The following is a description of a gene set: from publication Creighton CJ, Massarweh S, Huang S, Tsimelzon A, Hilsenbeck SG, Osborne CK, Shou J, Malorni L, Schiff R (PMID 18794137) Human Gene Set: CREIGHTON_ENDOCRINE_THERAPY_RESISTANCE_1 studied in species Homo sapiens The 'group 1 set' of genes associated with acquired endocrine therapy resistance in breast tumors expressing ESR1 and ERBB2. The effectiveness of therapies targeting specific pathways in breast cancer, such as the estrogen receptor or HER2, is limited because many tumors manifest resistance, either de novo or acquired, during the course of treatment. To investigate molecular mechanisms of resistance, we used two xenograft models of estrogen receptor-positive (ER+) breast cancer, one with and one without HER2 overexpression (MCF7/HER2-18 and MCF7 wt, respectively). Mice with established tumors were assigned to the following treatment groups: estrogen supplementation (E2), estrogen deprivation (ED), ED plus tamoxifen (Tam), all with or without the epidermal growth factor receptor tyrosine kinase inhibitor gefitinib (G). Another group received ED plus the antiestrogen fulvestrant (MCF7 wt only). Tumors with acquired or de novo resistance to these endocrine therapies were profiled for gene expression and compared with tumors in the E2 control group. One class of genes underexpressed in endocrine-resistant tumors (relative to E2-treated tumors) were estrogen inducible in vitro and associated with ER+ human breast cancers (luminal subtype). Another class of genes overexpressed in tumors with acquired resistance in both models represented transcriptional targets of HER2 signaling and was associated with ER-/HER2+ human cancers (ERBB2+ subtype). A third class of genes overexpressed in MCF7/HER2-18 tumors exhibiting de novo resistance to tamoxifen was associated with ER+ human cancers but not with estrogen-regulated genes. Thus, in response to various endocrine therapy regimens, these xenograft breast tumors shut down classic estrogen signaling and activate alternative pathways such as HER2 that contribute to treatment resistance. Over time, the molecular phenotype of breast cancer can change., and this is the list of marker genes: ASNS (NCBI Gene Id 440), HPS3, PAPSS1, IQGAP3, LARGE1, LYPD6, UBAP2, TGIF2, SNHG32, ENTREP1, C8orf88, ZCCHC24, UTP14C, TPD52L1 (NCBI Gene Id 7164), ABCA12, PRR11, RAB30, ADCY3, CAD, CDK2, ZNF121, NUSAP1, SGPP1, ADISSP, CHROMR, MCM4, UBE2C, FAM120AOS, MEX3C, PTTG1, PTPRG, BCL11B, RPS9, GSTZ1, TTL, GINS1, NDUFAF4, LINC00992, LDOC1, ATP8B2, SGK3, PPP1R12A-AS1, DOCK8, KLK10, TMEM64, FRMD6, SNX10, PPAN, TUBB, CDH3, TNNT1, OSBPL6, FGFR2, SLC7A1, NOP53, MAP4 (microtubule associated protein 4), EMP2, MYOF, ACTMAP, VXN, LAMP2, PTBP1, SYBU, FSTL3, ZNF703 (NCBI Gene Id 80139), CALCR, OGT, ARMC10, SDAD1, SIGLEC15, FAXDC2, SLC37A4, ATIC, SIAH2-AS1, ZNF22, CENPF, AFF3, WWP1, PMVK, UBE2E2, ZNF385B, HMMR, FARSB, IGSF1, RBPMS, MCM7, MYC, POLD2, FEZ1, GOLIM4, CCDC85B, SNAI2, NLN, CRISPLD2, TCAF1 (NCBI Gene Id 9747), JDP2, PA2G4, TBL1X, MID1IP1, KIF20A, ADGRG6, MIS18BP1, COL4A6, HACD1, CDK4, ITGA2, TIAM1, H4C12, POLR1H, MTCL2, NRIP1, NHP2, DENND5A, ARHGEF2, ESR1, MAMLD1, MTHFD1, SCUBE2, SGF29, RHBDF2, FAM178B, ERBB4, PALLD, NOP58, SNX24, SLC29A1, UNG, ZBTB2, BMERB1, BATF, ESD, BDH2 (NCBI Gene Id 641558), UBA5, TMEM164, GPATCH4, KIF4A, ARL2, CAMTA1, XIST, AHNAK2, EIF2S1, HUWE1, CCNB2, LTBP1, ELAPOR1, SHMT2, NR2F2 (nuclear receptor subfamily 2 group F member 2), PGR, TTLL12, RSU1, SMYD3, EFHD1, UTP14A, MGP, CISH, CCNB1IP1, ADAMTS19, PMP22, EPPK1, CCDC112, DAZAP1, KYNU, DDX27, PRSS23, NBDY, PARP1, ADK, NHP2P2, DTNA, SLC38A2, RWDD2B, GTPBP3, ZFP1, COPS2, HNRNPA1P3, OLFM1, BARD1, PIP4K2A, PABPC4, MRPL52, PAICS, RHOBTB3, STC2, LINC00052, DHPS, PBX1, PPP2R5E, MB21D2, PABPN1, ARPC5, RAB29, SLX4IP, SNRPD2, TET2, SULF1, ISOC1, APBB2, HDDC2, SLC27A6, ABAT, HPRT1, DHX33, QSER1, LINC02986, THYN1, ST13, ECI2, PDCD4, DOK7 (NCBI Gene Id 619409), DMKN, C1QTNF6, SFXN3, FBL (fibrillarin), CA12, MRPL24 (NCBI Gene Id 79590), TEAD4, AGR3, ELP2, SLC7A2 (solute carrier family 7 member 2), UBE2T, ABCC13, IGF1R, ARMCX1, WASF1, LGALS7, TRPC6, POLR1G, WDR4, MAPT, RPS4X, NUDT21, BMP8B, PPP1R35, ARID2, WDR89, MEST, TKFC, GPER1, RERG, C19orf48P, MDFIC, CDC25B, PPP1R18, NAB2, TCEAL1, PYROXD2, SYTL4, SYTL5, FKBP4, LDLRAD3 (low density lipoprotein receptor class A domain containing 3), SNRPE, IPO5, SULT2B1, HDAC11, TMPRSS3, DNAJC12 (NCBI Gene Id 56521), ERC1, COL4A5, POT1, FREM2, WWP1-AS1, SUPT16H, GPX8, TUBB6, MYO5A, EIF3M, PABPC1L, SPIN1, PLCB1, SH3BP5, NXT1, VPS72, FKBP3 (NCBI Gene Id 2287), KRT17, IRX4, PRMT5, JARID2 (jumonji and AT-rich interaction domain containing 2), CAV1, RHNO1, TPBG, ARL4A, ATRNL1, TPX2, TNPO2, TMT1A, FLNA, TEX10, SFXN2, SOCS2, PDZK1, DTD1, MRPS21, TFAP2C, RAMP3, BBIP1, PPP1R1C, LMBR1, NAP1L2, GPRASP2, CAP2, SMIM30, ASPM, NOB1, NR2C2AP, NALF1, DUT, SLC39A6, DST, ACSS3, LRRFIP2, PISD, MMS19, RIDA, ATP5PO, HSPB1, KLHDC3, RBBP8 (RB binding protein 8, endonuclease), ELOVL2, VEPH1, NECAB1, LPCAT1, THSD4, DLC1, IRS1, CADM1, DCAF4, RBM8A, GATA3-AS1, PRMT2, RPS23 (ribosomal protein S23), BCS1L, ELAPOR2, PPP2R3A, LGALS1, BTG2, ARMT1, NRARP, ELF1, RNF44, GINS3, SYTL2, PRDX6, SIAH2, H2AJ, SRGAP2, TP53, YDJC, TBC1D5, XRCC5, NUAK1, RRP1B, PAWR, TRIM59, TCEAL4, CHMP4A, SEMA3B, FBXL6, HEY2, STMN3, TBCB, JPX, ZBED3, GSTK1, GFRA1, STARD13, ANXA6, ABI2, FHL1 (NCBI Gene Id 2273), IMPDH2, MARVELD1, RPS12, ZMIZ2, SOX12, SP2-AS1, POTEM, FUT8, NPY1R, MAPKAPK2, CSTA, DPH5, ANP32B, TPM3, C1orf226, HAUS4, RNF168, HOXC6, MAP3K1, IRX2, DHRS7, PRLR, APEX1, EEIG2, BCL2, NAALADL2, NBPF9, METTL3, ADSL, PCK2, MDP1, AURKB, NTAN1, ZIC2, GRIA2, SEMA6A, DKK1, PRORP, MSRB2, HNRNPA0, GREB1, RIPK2, ELP6 (elongator acetyltransferase complex subunit 6), PTEN, EMB, MREG, UBQLN4, CXCL12, FYB2, FKBP5, RMI2, ENPEP (NCBI Gene Id 2028), TOP1MT, TAF3, MYBL1, SLC38A1, AIDA, GATA3, OSR2, CLK2 (CDC like kinase 2), CPNE1, IL1RN, DUSP23, COL12A1, INPP4B, NADSYN1, SLC24A3, ARHGAP36, RIMS2, SOX3, CDKN3, ADCY1, SRM, SLC5A6, LINC01087, ANKRD28, ATF5, ATXN1, ATXN1-AS1, KIF3C, JAK1, CALHM2, ARHGAP24 (Rho GTPase activating protein 24), LYPD1, ZNF711, AREG, SLC35F6, FAM83B, L1CAM (NCBI Gene Id 4268), SNHG29, PLP2, HOMER3, MCM3 (minichromosome maintenance complex component 3), PROSER2, DCTPP1, PKIB, RRS1, ZBTB10, EVL, KLK11, TBC1D9, OS9, MSI2, SVIL, HMCN1, KCTD15, CELSR2, RAB31, SARS1, GTF3A, MRPL51, PHF19, COMMD6, PTGER4, HMGN4 (NCBI Gene Id 10473), FADS3, HMGB2, DSCAM, RSRC1, CCDC18-AS1 (NCBI Gene Id 100131564), FTO, RTN2, AP1S2, SNHG7, DSCAM-AS1, CEP68, DAXX, RALGPS2, CBL, ELOVL2-AS1, DSP (desmoplakin), COL5A1 (collagen type V alpha 1 chain), CCDC83, SYT1, ZNF516, LIG3, NRCAM, FLNB, BZW2, ZNF114 (zinc finger protein 114), PPM1K, UGDH, SEMA3D, AARS1, HIRIP3, E2F6, HELZ2, DYNLT3, PCP4, SYNPO2, ESYT1, BMPER, RPL22L1, RMND1, CA2 (NCBI Gene Id 760), SNHG6, MRPS25, CMSS1, NAT10, RPL19, MEGF6, EPS15L1, CD99, UBE2S, RBMX, DHTKD1, EGR3